Given this list of marker genes CAPNS1, RBM3, NFIX, CCT7, TMEM14A, DCUN1D1, PABPC1, MALAT1, ZNF207, HAT1, MACROH2A1, SMG1, NEDD4, PRKAR1A, RPGRIP1, CELF2, HMGB1, GIMAP6, CLIP2, here is a description of the gene set: Hematopoietic stem cells (HSCs) have self-renewal capacity and multilineage developmental potentials. The molecular mechanisms that control the self-renewal of HSCs are still largely unknown. Here, a systematic approach using bioinformatics and array hybridization techniques to analyze gene expression profiles in HSCs is described. To enrich mRNAs predominantly expressed in uncommitted cell lineages, 54 000 cDNA clones generated from a highly enriched population of HSCs and a mixed population of stem and early multipotent progenitor (MPP) cells were arrayed on nylon membranes (macroarray or high-density array), and subtracted with cDNA probes derived from mature lineage cells including spleen, thymus, and bone marrow. Five thousand cDNA clones with very low hybridization signals were selected for sequencing and further analysis using microarrays on glass slides. Two populations of cells, HSCs and MPP cells, were compared for differential gene expression using microarray analysis. HSCs have the ability to self-renew, while MPP cells have lost the capacity for self-renewal. A large number of genes that were differentially expressed by enriched populations of HSCs and MPP cells were identified. These included transcription factors, signaling molecules, and previously unknown genes. from publication Park IK, He Y, Lin F, Laerum OD, Tian Q, Bumgarner R, Klug CA, Li K, Kuhr C, Doyle MJ, Xie T, Schummer M, Sun Y, Goldsmith A, Clarke MF, Weissman IL, Hood L, Li L (PMID 11781229) studied in species Mus musculus Human Gene Set: PARK_HSC_VS_MULTIPOTENT_PROGENITORS_UP Genes up-regulated in long term hematopoietic stem cells (LT-HSC) compared to multipotent progenitor (MPP) cells.